Given this list of marker genes FXYD5, TTC21B (tetratricopeptide repeat domain 21B), NBEAL1, SMG6, SPIN4, IGF1R, GSTA3, ALMS1, DKK4, RAB23, DFFB, SIPA1L3, SLC18B1, SLC38A1, ATP2B1, VWA2, TIMP2, ANAPC1, AHCYL1, FADS2, ROGDI (rogdi atypical leucine zipper), UBR2, HDAC6, NUP205, PRKDC, PRKAB2, HYI, SPEF2, DCPS, LMBR1, DMRTA1, UBE4B, CLUAP1, CNOT1, RANBP1, CEP95, SGSM3, ACOX3, HS2ST1, TMEM143, ADAM32, DVL2, LRP5, EIF4A1, ZFP62, CUL7, ANKRD29 (ankyrin repeat domain 29), CNTLN, NCEH1, ICAM4, CD68, FAHD1, PLXNA2, MTBP, CBY1, REEP5, MPV17L2, SLC37A4, TAF1, TMEM131, SPAG9, VSTM2A, ASXL2 (NCBI Gene Id 55252), TAMALIN, RASSF7, OTUD4, FAM216A, CRYZ (NCBI Gene Id 1429), PDIA4, TCTN2 (tectonic family member 2), LMNB1, MDGA2, SENP2, FAM53A, CD300LB, GLMP, RAD54L, ZMYND11, LIG3, ITGAV (NCBI Gene Id 7449), CFAP119, ASH2L, CCDC137, TEC, PCNT, PMP22, BMS1, MKNK2, PRM3, CEP128, SLF2, ELP1, ACACA, ELP2, ARSB, ZNF652, UGGT1, BLNK, MCM6, MTCP1, CUX1, PRPF8, EDEM3, MTR, VPS37A, SNRNP48, PDS5A, NCOR1, CARD19, ENKD1, SEPTIN12, PHF19, SUPT20H, CIPC, KLHL25, NOC3L, MAST2, B4GALT4, C15orf61, WDR24, LTA4H, CC2D2A, PECR, CAPZA1, HNRNPH1, PRKD3 (protein kinase D3), CDT1, PARD6B, CENPN, HMGCR, SEC24A, LRP1, SARS1, FEM1B, PABPC1, NEMF, SEL1L, ZNF585A, SLCO4A1, ACTR1B, ITGB2, SH3GLB2 (SH3 domain containing GRB2 like, endophilin B2), UTP3, KCNN3, PHKA2, NAV2, ZNF667, PIP4P2, ZBTB11-AS1, SDHA, RBBP5, TSHB, SLC5A6, CLN8, BID, THRAP3, STEAP3, NUP210, DLX2, SLC10A3, DDX59, SMYD3, ABITRAM, NF2 (NCBI Gene Id 654093), MTHFD1L, ZW10, PTPN22, PDE1A, SLC35G1, HUWE1, ZFAND2A, RTN4, NOL6, PPCS, SNRNP200, RGS2, PUM1, NUMA1, CENPO, PDLIM5, ADPRS, CUL1, SH2B1, ATP5F1A, PALB2, LAT2, TMX4, CD36, POLE, ACAP2, RPS6KA6, NUCKS1, ELMO1, ZNRF3, SLC25A13, CMTM3 (CKLF like MARVEL transmembrane domain containing 3), LYZL4, CPA5, CELF2, SLC12A2, here is a description of the gene set: Genes up-regulated in T cells: CD4 versus CD8. species: Homo sapiens Human Gene Set: GSE8835_CD4_VS_CD8_TCELL_UP from publication Görgün G, Holderried TA, Zahrieh D, Neuberg D, Gribben JG (PMID 15965501) To examine the impact of tumors on the immune system, we compared global gene expression profiles of peripheral blood T cells from previously untreated patients with B cell chronic lymphocytic leukemia (CLL) with those from age-matched healthy donors. Although the cells analyzed were not part of the malignant clone, analysis revealed differentially expressed genes, mainly involved in cell differentiation in CD4 cells and defects in cytoskeleton formation, vesicle trafficking, and cytotoxicity in CD8 cells of the CLL patients. In coculture experiments using CLL cells and T cells from healthy allogeneic donors, similar defects developed in both CD4 and CD8 cells. These changes were induced only with direct contact and were not cytokine mediated. Identification of the specific pathways perturbed in the T cells of cancer-bearing patients will allow us to assess steps to repair these defects, which will likely be required to enhance antitumor immunity. Gene expression profiling was performed to determine whether CLL cells induce changes in T cells in patients with CLL.